Given this list of marker genes STX3, SYT2, RIMS1, STX1B, ICA1, GIT1, SLC28A2, SLC18A2, CAMK2A, SLC6A12, CDK5, TACR2, SLC17A5, SYT4, SCRIB, TPRG1L, PIP5K1C, SLC29A3, SLC29A1, RAB3B, PRKN, SLC18A1, SNCAIP, SYT9, SYT13, HCRT, SLC22A4, PPT1, ATP1A2, NRXN1, BLOC1S6 (biogenesis of lysosomal organelles complex 1 subunit 6), SLC22A3, NAPA, SNCG, MCTP1, CHAT, APP, CACNA1B, FMR1, RAP1A, CALM3, SLC6A3, RAP1B, SLC6A4, SNAP29, SLC32A1, GPER1, ERC2, SYN1, NPY, CPLX2, STXBP3, SLC29A4, SNPH, CLN8, CSPG5, PRRT2, VAMP2, DRD1, SNAP47, NAPB, PFN2, PSEN1, SLC1A3, PDZD11, SYNGR3, SLC6A15, SLC6A7, NGF, NRXN2, VPS18, P2RX1, SNAP25, CHRNA3, SLC1A6, SLC30A1, CHRNB4, OSBPL2, PARK7, DOC2B, PTPRN2, ASIC1, SYNJ1, BRAF, ABCC8 (NCBI Gene Id 6833), DTNBP1, BGLAP, KMO, CASK, CPLX3, SLC6A13 (solute carrier family 6 member 13), ITGB3, ADORA2A, SLC22A1, PCLO, LIN7B, SYT7, DOC2A, KCNJ10, SYT12, AP2B1, SEPTIN5, KCNMB4, SLC22A2, SLC29A2, SV2B, RIMS3, DRD2, FBXO45, SYT10, PER2, STXBP1, SLC17A6, P2RX7, HRH3, DVL1 (dishevelled segment polarity protein 1), TSPOAP1, SYT8, SNAP23, RIMS2, SLC18A3, SLC17A8, RPH3A, MCTP2, DRD4, STX11, SYP, STX1A, BRSK1, RAB3GAP1, GRIK5, SLC6A8, PPFIA2, FLOT1, MYOF, LIN7A, DYSF, RAP1BL, SLC6A11, OTOF, RIMS4, GDNF, CADPS2, DRD3, MEF2C, PREPL, ITGB1, NF1, GABRQ (NCBI Gene Id 55879), CPLX1, KCNJ8, STXBP5, STX4, BAIAP3, MICU3, GPR151, CADPS, SLC6A5, GRM4, SLC6A16, SLC4A8, SLC6A6, BEST1, UNC13C (NCBI Gene Id 440279), RPH3AL, UNC13A, SYT5, GPR158, GFAP, SLC6A2, SLC38A2, PPFIA3, SLC38A1, SLC6A1, EFR3A, CACNB4, LIN7C, GGCX, SNAPIN, SLC17A7, PRKCG, SLC5A7, SLC1A1, WNT7A, SV2A, SYN2, PNKD, GPM6B, SLC1A2, SYN3, FER1L5, SLC6A18, SYT11, SLC6A9, TOR1A, UNC13B, ATP2A2, STX19, STXBP2, SV2C (synaptic vesicle glycoprotein 2C), SLC1A7, NOS1, P2RY1, PPP3CA, RAB3A, SYT1, RAB5A, LRRK2, PRKCB, STX2, SNCA, FBXL20, NLGN1, DNAJC5, SLC18B1, CPLX4, SLC6A17, here is a description of the gene set: Human Gene Set: GOBP_NEUROTRANSMITTER_TRANSPORT studied in species Homo sapiens The directed movement of a neurotransmitter into, out of or within a cell, or between cells, by means of some agent such as a transporter or pore. Neurotransmitters are any chemical substance that is capable of transmitting (or inhibiting the transmission of) a nerve impulse from a neuron to another cell.